The following is a description of a gene set: Mouse Gene Set: GOMF_HYDROLASE_ACTIVITY_ACTING_ON_CARBON_NITROGEN_BUT_NOT_PEPTIDE_BONDS_IN_CYCLIC_AMIDES Catalysis of the hydrolysis of any non-peptide carbon-nitrogen bond in a cyclic amide. studied in species Mus musculus, and this is the list of marker genes: Dpysl4, Crmp1, Dpysl2, Dpep1, Mblac2, Dclre1b, Dpys, Oplah, Dclre1a, Amdhd1, Urah, Dhodh, Cad, Dpysl3, Dpysl5